The following is a description of a gene set: Mouse Gene Set: GOCC_PRESPLICEOSOME A spliceosomal complex that is formed by association of the 5' splice site and the branch point sequence with specific snRNPs. The prespliceosome includes many proteins in addition to those found in the bound snRNPs. Commitment to a given pair of 5' and 3' splice sites occurs at the time of prespliceosome formation. Prespliceosome complexes are not active for splicing, but are instead an early step in the assembly of a spliceosomal complex. species: Mus musculus, and this is the list of marker genes: Sf3b1, Snrpg, Luc7l2, Snrnp70, Ddx42, Sf3a1, Snrpc, Prpf39, U2af2, Sf3a2, Prpf40b, Lsm7, Snrpn, Luc7l3, Prpf40a, Snrpb, Luc7l